The following is a description of a gene set: Mouse Gene Set: GOMF_P_TYPE_TRANSMEMBRANE_TRANSPORTER_ACTIVITY studied in species Mus musculus Primary active transporter that auto-phosphorylates (hence P) at a key conserved aspartate residue, generating a conformational change that allows transport of the substrate. Hydrolysis of the phosphorylated Asp residue, catalyzed by the actuator (A) domain, results in another state with occluded substrates. Upon dissociation of Mg2+ and Pi, the enzyme reverts to the initial state, in which the counter-transported substrate is released into the cytosol., and this is the list of marker genes: Atp13a3, Atp2b2, Atp5f1e, Atp1a2, Atp2b4, Atp1b1, Atp6v0b (NCBI Gene Id 66370), Atp2b3, Atp1a1, Atp2a2, Atp2a1, Atp4b, Atp2c2, Atp7a, Atp1a4, Atp6v0a4, Atp13a1, Tmem94, Atp1b2, Atp6v0c, Atp2b1, Atp2c1, Atp13a2, Anxa5 (NCBI Gene Id 97115), Cpox, Atp1a3, Atp4a, Atp1b3, Atp5mg, Atp13a4, Atp2a3, Atp12a, Atp13a5, Atp7b